The following is a description of a gene set: This event has been computationally inferred from an event that has been demonstrated in another species.<p>The inference is based on the homology mapping from PANTHER. Briefly, reactions for which all involved PhysicalEntities (in input, output and catalyst) have a mapped orthologue/paralogue (for complexes at least 75% of components must have a mapping) are inferred to the other species. species: Mus musculus part of: DNA strand elongation Reactome Pathway: Leading Strand Synthesis electronically inferred by orthology from the curated human pathway, and this is the list of marker genes: Pola2 (NCBI Gene Id 18969), Pold2, Pold4, Rfc1, Pold1, Prim1, Pola1, Pcna, Rfc3